The following is a description of a gene set: Human Gene Set: HP_AMYOTROPHY_INVOLVING_THE_SHOULDER_MUSCULATURE species: Homo sapiens Amyotrophy involving the shoulder musculature, and this is the list of marker genes: FHL1, FKTN, CAPN3, LMNA, TRPV4